The following is a description of a gene set: Down-regulated genes distinguishing between two subtypes of gastric cancer: advanced (AGC) and early (EGC). species: Homo sapiens Human Gene Set: VECCHI_GASTRIC_CANCER_ADVANCED_VS_EARLY_DN from publication Vecchi M, Nuciforo P, Romagnoli S, Confalonieri S, Pellegrini C, Serio G, Quarto M, Capra M, Roviaro GC, Contessini Avesani E, Corsi C, Coggi G, Di Fiore PP, Bosari S (PMID 17297478) Gastric carcinoma is one of the major causes of cancer mortality worldwide. Early detection results in excellent prognosis for patients with early cancer (EGC), whereas the prognosis of advanced cancer (AGC) patients remains poor. It is not clear whether EGC and AGC are molecularly distinct, and whether they represent progressive stages of the same tumor or different entities ab initio. Gene expression profiles of EGC and AGC were determined by Affymetrix technology and quantitative polymerase chain reaction. Representative regulated genes were further analysed by in situ hybridization (ISH) on tissue microarrays. Expression analysis allowed the identification of a signature that differentiates AGC from EGC. In addition, comparison with normal gastric mucosa indicated that the majority of alterations associated with EGC are retained in AGC, and that further expression changes mark the transition from EGC to AGC. Finally, ISH analysis showed that representative genes, differentially expressed in the invasive areas of EGC and AGC, are not differentially expressed in the non-invasive areas of the same tumors. Our data are more directly compatible with a progression model of gastric carcinogenesis, whereby EGC and AGC may represent different molecular stages of the same tumor. Finally, the identification of an AGC-specific signature might help devising novel therapeutic strategies for advanced gastric cancer., and this is the list of marker genes: HSD17B2, SLC4A4, LINC01133, ESCO2, TFF3, CA13, CHCHD10, BLNK, BCL2L15, CFTR, DERL1, CHCHD5, VILL, ZBTB7B, DDT, SST, ALDOB, SSTR1, MYEOV, CLRN3, PRADC1, CYC1, EIF3H, LIG3, HBA1, STARD10, CA2, TMEM238L, ADH1C, ABCG5, TSIX, PRSS3, CRIP1, PRSS2, HBB (NCBI Gene Id 3043), S100P (NCBI Gene Id 6286), RACGAP1P1, CPS1, DHRS11, HEPACAM2, WNK4, CDC42EP5, ADRA2A, SENP8, REG1A, TMC5, TM4SF20, SSNA1, CHAC2, CCSER1, FXYD3, TMEM45B, ELAPOR1, ARFGEF3, REG4, VSIG2, SLPI, SMDT1 (single-pass membrane protein with aspartate rich tail 1), NMU, MLPH, ENTPD3, TMPRSS2, C6orf58, SDHAP3, LPCAT4 (NCBI Gene Id 91188), DPP3, RER1, ISG20, ETHE1, TFF2, CLDN18, SYBU, TPD52, FMO5, C9orf152, GPA33, SERPINB1, AKR1C3, OTC, RPSAP44, ATP10B, ARX, PTPRN2, NAT1, CALML4, DSC2, LGALS4 (galectin 4), POLD4, MS4A8, PCBD1, COX8A, REEP6, XRCC4, ABHD13 (abhydrolase domain containing 13), FAM3D, AADAC, PIP5K1B, GATA4, CYB561D1, SNRNP25, IFT57, GOT1, CLDN23, REG3A, ABCG2, KCNK10, CKMT1B, NDUFA7, AK1, DOT1L, GMDS, GSDMB, NUDT6, NAT2, CYSTM1, GP2, CAPN13, HMMR, RBM19, GCNT3, ABHD12, CLDN15, ODAM, KCNE3, CAPN9, BTNL8, STEAP3, RHPN2, VPS28, HGD, AKR1C1, CENPV, SMIM31, EPN3, ALDH3A1, DANCR, SULT1A2, PLAAT2, RPS27L, CES2, GOLM1, GCNT1, BTD, SULT1C2, MUC1, BLVRB